Given this list of marker genes Dagla, Cyp4f18, Alox8, Cyp2d22 (cytochrome P450, family 2, subfamily d, polypeptide 22), Cyp2j9 (cytochrome P450, family 2, subfamily j, polypeptide 9), Cyp2c39, Cyp2j11, Cyp4a32, Cyp2c29, Pnpla8, Cyp2a5, Fads1, Cyp4a12b, Ephx1, Cyp2d11, Cyp2g1, Cyp2f2, Cyp4a12a, Cyp2d12, Cyp4f14, Ahr (aryl-hydrocarbon receptor), Cyp2u1, Cyp2b19, Cyp1a2, Cyp2j8, Cyp4f40, Cyp2j12, Cyp4f13, Cyp4a31, Cyp4f15, Mgst3, Ptges (prostaglandin E synthase), Sphk1, Cyp2b13, Cyp2a4, Cyp2a12, Ptgds, Cyp2j6, Cyp2j5, Ptgis, Cyp2c50, Alox12e, Alox5, Cyp2d26, Sco1, Cyp2a22, Cyp2b9, Cyp2s1, Alox12, Gpx1, Pla2g4a, Cyp2b23, Cyp4a30b, Ptges3, Mgll, Alox12b, Ptgs1, Cyp2c38, Cyp4a10, Cyp2d34 (NCBI Gene Id 223706), Ptgs2, Cyp4a14, Cyp2c37, Cyp1b1, Cyp2t4, Cyp2b10, Cyp2c40, Daglb, Cthrc1, Cyp2c23, Cyp2d10, Cyp2e1, Cyp2j13, Cyp4a29, Cyp2j7, Cyp2d9, Gpx4, Alox15, Ptges2, Cyp2c54, Cyp2c55, Aloxe3, Pla2g2f, here is a description of the gene set: Mouse Gene Set: GOBP_ARACHIDONATE_METABOLIC_PROCESS The chemical reactions and pathways involving arachidonic acid, a straight chain fatty acid with 20 carbon atoms and four double bonds per molecule. Arachidonic acid is the all-Z-(5,8,11,14)-isomer. species: Mus musculus